The following is a description of a gene set: Human Gene Set: MIR18A_3P species: Homo sapiens Genes predicted to be targets of miRBase v22 microRNA hsa-miR-18a-3p in miRDB v6.0 with MirTarget v4 prediction scores > 80 (high confidence targets). from publication Chen Y, Wang X (PMID 31504780), and this is the list of marker genes: NECAB1 (N-terminal EF-hand calcium binding protein 1), FAM76A, ESR2, ABCB11 (ATP binding cassette subfamily B member 11), GABARAPL1, SERF2, SAMD4B (NCBI Gene Id 55095), KLF5, EMX1, RIMS4, GSK3A, ADAMTS5, SCML4 (NCBI Gene Id 256380), KIF3B, DENND1B, ADCY1, SLC9A5, ATXN7, RIMS2, BTN3A1, NUDT10, PPFIA4, FNDC5, GIT2, DNAJC14, TBC1D16, SCD, ZC3H10, CSNK1D, POM121, CYB561D1, ZNF644, C3orf18, TBC1D19, MEF2C, UBE2Z, NTRK2, TMEM178B, SNX8, NCOA7, MLLT6, ESR1, EFNA1, ZMPSTE24, KDM2A, ACVRL1, MGAT5, SEM1, BTBD9, MTCL2, NAA16, MTF1, SPTB, MOB1B, UXS1, PHLDB2, PSMD11, METTL21A, ZNF827, UBE2D4, CCDC136, ELAPOR1, KCNJ5-AS1, MSRB3, KCNAB2, TEF, SNX20, THSD7B, PDP1, WDR48, USP44, TIMP2, MAN2A2, FOXP4, ZBBX, CSMD1, PRRC2B, TMEM170B, SLIT1, LMX1A, CRELD1, SERINC5, BRD8, GRAMD1B, INO80E, ZFHX3, SLFN5